The following is a description of a gene set: Human Gene Set: MIR6844 species: Homo sapiens Genes predicted to be targets of miRBase v22 microRNA hsa-miR-6844 in miRDB v6.0 with MirTarget v4 prediction scores > 80 (high confidence targets). from publication Chen Y, Wang X (PMID 31504780), and this is the list of marker genes: IQCJ, MYLK3, IYD, DENND2D, SH3BGRL, UTY, CDK4 (cyclin dependent kinase 4), PCDH17 (NCBI Gene Id 27253), IRX3, HS3ST3B1, ETS2, TSHZ2 (NCBI Gene Id 7765), MAPK6, FAM20B, ANKRD13A, CHST7, USP49, PTPRQ, ALG10 (ALG10 alpha-1,2-glucosyltransferase), CHORDC1, MFSD14A, ANKRD12, ZNF331, IDS, UNC119, GALK2, SYNJ2BP, STRIP2, HLTF, DDX21, NMT2, PSG6, ZEB2, CDH11, ZMYND11, ONECUT2, RASSF8, BMPR1B, MLLT3, CD83, MLX, SLC24A2, DDX18, TMEM169 (transmembrane protein 169), SNTG1, XPO4, HYCC2, YBX3, EPCIP, C6orf62, EP300, PHF20, CALB2, ITGA8, XRCC4, HERC1, ABTB2, FLG2, FYTTD1, C9orf153, RAB5B, PABIR2, TDRD3, ALG10B, ATP8B2, FBXO33, MFSD14B, MMP21, MICAL2, UNC80, CSRNP2, MME, URI1, TLNRD1, EHF, NR2C2, PPARGC1B, HTRA4, PTPRD, PSD3, NXNL2, ACTC1 (NCBI Gene Id 70), GJA5, DCAF12L1, IAPP, COL8A2 (collagen type VIII alpha 2 chain), SNX21, SEPSECS, FUT9, NLK, BORCS7, TBC1D8B, FOXP2, CRYBG3, SLC35B4, IL1RAP, CREBZF, ARL8B, PDE8A, DNAL1, FPGT, ATG14, MRPS35, MAPK1, ERC1, ZNF277, CYB5B, GOLGA6L4, NPL, FREM2, TBC1D12, TRDN, CCDC28A-AS1, SNAI2, DSCAML1, SP1, NPIPB11 (nuclear pore complex interacting protein family member B11), BRCA2, STOML3, ABLIM2, FOXD1 (forkhead box D1), LRRC74B, SYN2 (NCBI Gene Id 6854), PGAP1, ARFGEF2, CYBRD1, SGIP1, TXLNB, SSPN, RYR2, INVS, ZKSCAN8, DISC1, TDRD7, BLTP3B, JAM2, MGAT4A, CDH23, PTK2, SLC35B3, MRTFB, SORCS2, ENPP4 (ectonucleotide pyrophosphatase/phosphodiesterase 4), ZNF200, PLCB1, ATP6V1B2, ZNF208 (zinc finger protein 208), ANGPTL1, PRP4K, DDAH1, INO80D, ADAP2, DMTF1, PDPK1 (NCBI Gene Id 5170), NBEA, PTGS2, SMARCA5, NPAS3, MBD5, ARGLU1, TNFAIP8, PPM1E, HBS1L, ARCN1, MORF4L2 (NCBI Gene Id 9643), RIC3, SMCP, IGF2BP2, MTX3, EMB, LRRC39, AGPS, VPS13A, TCEAL1, MTMR2, TMEM144 (NCBI Gene Id 55314), PSG9, TMEM63B, IMP4, KCNQ3, DSE, RBMS3, CREG2, PPP2R2A, RNF148, PRTG (NCBI Gene Id 650816), CELF6 (NCBI Gene Id 60677), ACLY, LINC01517, MYBL1, BCLAF3, MAP1B, ZNF257, FZD4, AP4S1, TRHDE, ZFHX4, EMC4, RIMS2, ETS1, NPIPB5, EXD2, NPIPB13, FZD5, TRIM9, BRD10, COA5, CLDN20 (claudin 20), S1PR1, COPS3, HS2ST1, CA10, STX17, NR2E1, AFF2, MST1L, CCL2 (NCBI Gene Id 6347), SLC10A7, NPIPB4, PIWIL4, RAB27B, VAV3, NRP1, TTR, GLI3, CAPS2, BAG4 (BAG cochaperone 4), DNAJC3, JPH4, RS1, ACACB, ADGRL2, KCNJ1, IREB2, ITGA6, CLOCK, LGALSL, DDX43, TMEM41B, RNF217, ASXL3, SLIT2, MPP7, SLC8A1 (solute carrier family 8 member A1), GMNC, UBE2G1, MAGI3, CUL4A, BRWD3, NOX4, PHF3, EBNA1BP2, TLE4 (NCBI Gene Id 7091), HLA-DOA, ZNF148 (NCBI Gene Id 7707), NPIPB3, LDLR, SYAP1, SNX1, VDAC3, VEGFA, OPRM1, SEC31A, TES, GADD45A, MAGI1, ANKRD34B, PBX1, EML6, GLIPR1, CPNE4, TFDP2, NCOA3, SYPL1, LPL, NTNG1, COL3A1, ZNF607, UBE2H, CACNG3, RHOBTB1, SPINK5 (NCBI Gene Id 50962), GNPTAB, LRRTM3 (leucine rich repeat transmembrane neuronal 3), RANBP17, PIGH, CD200R1 (CD200 receptor 1), NFATC2, FRYL, PAX9, MTA1, RIN2, STK3, SRGAP1, KDELR2, ZBTB39, CTBP2, DDX3Y, NEGR1, PNP, FBXO38, CLTC, SENP1, TMEM135, SACM1L, PSG3, LSM14A, NLGN1, BMAL1, MAN1A2, LIN54, COL6A3 (NCBI Gene Id 1293), SLC16A14, ATP8A1, C2orf88, LINC02909, SHTN1 (shootin 1), ALG8, PTPN22, VAMP7, LRRC19 (NCBI Gene Id 64922), WAPL, TRAF3, COG3, PSMA5, PDE11A, CREBBP (CREB binding protein), ARMH4, POLR3G, ZBTB41, ACAD9, GOLGA6L9 (golgin A6 family like 9), CHMP2B, CELSR2, ATXN7, ZC3H10, GDNF, ABT1, COL8A1, BIRC6, KIF13A, HPDL, TGFBR2, ACVR2B, ZNF121 (NCBI Gene Id 7675)